Given this list of marker genes HSPA1B, CEBPA, RPL11, DAB2, USP5, DNAJB2, DESI1, DDRGK1, UBQLN4, TMX1, BTRC, TRIB1, F8A1, CSNK2A1, PABPN1L, WNT10B, CSNK2A2, HSPBP1, PSMC5, TAF9, PSMC1, LRRK2, HAMP, TRIM39, AXIN2, WFS1 (NCBI Gene Id 94141), PSME1, AURKA, CLU, ELOB, USP13, SENP1, RNF180, BBS7, SIRT6, MARCHF7, BAG2, PAQR3 (NCBI Gene Id 152559), NUPR1, STYX, MDM2, SVIP, RBX1, HSP90AB1, NKD2, FBXW8, UBE2K, PRKACA, USP26 (NCBI Gene Id 83844), SGTA, KCNE2, FBXO22, TTC36, ATXN3L, PSMC3, DAB2IP, SUMO1, KEAP1, GPX1, GSK3A, TMF1, SIRT1 (NCBI Gene Id 23411), RYBP (RING1 and YY1 binding protein), NUB1, RAD23B, APOE, OSBPL7, NFE2L2, MAPK9, FMR1, DET1, CAMLG, PABIR1, ZFAND2A, EIF3H, SUMO2, ALAD, CBFA2T3, ZYG11B (zyg-11 family member B, cell cycle regulator), PSMC2, PSME2, AQP11, UBQLN2, CSNK1D, UCHL5, RNF185, ECSCR, USP7, SH3RF3, CDC20B, TREM2, USP9X, GLMN, GIPC1, UBQLN1, SH3RF1, USP38, RACK1, SIRT2, HSPA1A, PIAS1, HECTD1, PLK3, GABARAPL2, SHH, BCAP31, RNFT1, UBXN1, CDK2, PINK1, CCAR2, GNA12, UBXN2A, GBA1 (glucosylceramidase beta 1), TMEM259, UBB, BAG5, PANO1, STUB1, USP25, PSMD14, BAG6, USP19, IL33, FBXW7, SMAD7, TRIB3, TRIB2, GSK3B, XBP1, CSNK2B, N4BP1, ZER1, PRICKLE1, PBK, ZNF418, PSMD10, COP1, MAP1A, PSEN1, OPHN1, USP14 (NCBI Gene Id 9097), UFL1, PSMC6, KLHL40, NOP53, FHIT, WAC, CAV1, TAF1 (TATA-box binding protein associated factor 1), PSME3, RCHY1, PSME3IP1, CSNK1E, ARAF, COMMD1, SMARCC1, PSMF1, TF, DNAAF4, NUDT15, CDC20, ARHGAP5-AS1, GCLC, LAMP3, RNFT2, NFE2L1, AKT1, RFPL1, RAD23A, PKD1, SOCS5, EPM2A, MTM1, GABARAP, FOXF2, PITHD1, PRKN, UBQLN3, FZR1, PSMC4, F8A2, MIR128-1, OGT, TMTC3, TLK2 (tousled like kinase 2), DDA1, NEURL3, DVL1, XPO1, CHFR, PLK1, PRKCG (NCBI Gene Id 57013), PARK7, CSNK1A1, ATXN3, SOCS4, F8A3, HERPUD1, HFE, PHF20L1, VCP, RHBDF1, AXIN1, SH3RF2, here is a description of the gene set: studied in species Homo sapiens Any process that modulates the rate, frequency, or extent of the chemical reactions and pathways resulting in the breakdown of a protein or peptide by hydrolysis of its peptide bonds that is mediated by the proteasome. Human Gene Set: GOBP_REGULATION_OF_PROTEASOMAL_PROTEIN_CATABOLIC_PROCESS